Given this list of marker genes ACOX1, SETD5, PIKFYVE, SSBP2, DUSP6, RFX1, CTTNBP2, CDCA7L, RNF38, FHIP2A, SFXN1, XYLT2, FNIP2, CNIH1, KLHL14, RIMS2, LONRF3, GIT2, FKBP1A, NR4A3, GPR137C, PLEKHG3, HNF1B, SLC24A3, PRKAR2B, GOLGA4, TACC2, KLF4, PALLD, SLC10A7, DDX3Y, PAPSS2, BCL11A, CBLN4, RAB23, RAB3C, VWA5B2, NFYC, UBE2W, HYCC2, USP36, FMN2 (NCBI Gene Id 56776), DOCK5, MIA3, CBFA2T3, MMP10, ELOVL4, PPP1R37, TAGAP, DPP10, WASL, DSC2, C19orf12, GPC6, ADAMTSL3 (ADAMTS like 3), PIK3AP1, MBOAT2, RSBN1, ASPH, YIPF4, FOXN2 (NCBI Gene Id 3344), HIPK1, RNF180, OTUD4, PTGES2, ANKRD28, UBXN4, ITPRID2, CUX1, PITPNM2, SLC17A6, TWIST1, UBE2Z, TMF1, ELK4, CPNE8, ZFC3H1, FRY, SERTAD2, SOCS6, GLCE, FBXW7, KLHL29, OTUD3, MTMR9, EDEM1, NCKAP5, SLC4A8, HCN2, GNAQ, SLC12A5 (NCBI Gene Id 57468), SH3PXD2A, MPP1, GTF2A1 (general transcription factor IIA subunit 1), MAP3K20, PNISR, TNPO1, GOLGA7, DCAF6, DUSP10, RGS3, TPCN1, FBXO33, FHIP1B, TCF21, VPS4B, CSMD3, ARF1, ANP32E, RNF4, PCDH7, MIER1 (MIER1 transcriptional regulator), TAFA1, FCHO2, GATA6, IL36B, NUP43, PTPRK, CCDC186, MAP1B, AIDA, SLC9A7, NSF, MSR1, MFHAS1, SYNJ1, PPP1R12C, MAN2A1, PCMTD1, LIN54, SNAPC1, ZFHX4, IRS2, KLF8 (NCBI Gene Id 11279), JMY, SPTBN4, NKX2-4, NOX4, IBTK, MINAR1, NEFM, EPG5, SLC25A32 (NCBI Gene Id 81034), REXO1, PCGF3, PIK3R3, ARMC1, RANBP9, ZNF287, SEC31B, TWF1, REST, COL5A1, PUS7, KBTBD8, SEMA3A, GID4, CHCHD10, C6orf62, TMEM229A, COG3, SELENOT (selenoprotein T, NCBI Gene Id 51714), TSC1, GATA2, CDK16, TRIM36, UCHL5, MYCBP2, LYST, GRAMD2B, PDE10A, C8orf44-SGK3, NIPAL1, PCOLCE2, NEFH, UBASH3B (ubiquitin associated and SH3 domain containing B), FOSL2, ZDHHC5, ANKIB1, CACNA1I (calcium voltage-gated channel subunit alpha1 I), EVI5, FNBP4, PRRC2B, GPR158, PLEKHB2, SGK3, FZD10, SYN2, ESRP1, TTC9, DAAM1, GNPDA2, ST6GAL2, DSTYK, STX17, BSDC1, MAP2K4, ROBO2, KMT5B, HIVEP1, CPEB4, BCAT2, MED19, UGP2, NUFIP2, SLC38A2, ANKRD44, PTPRJ, MCL1, SOSTDC1, SNX13, MAGEC2, FAM81A, KLHL15, MAST4, ADAMTSL1, ATXN1 (NCBI Gene Id 7912), ZNF595, ZEB2, CADM2, STYX, DNAJB9 (DnaJ heat shock protein family (Hsp40) member B9), SLC32A1, RAD21, CDKL5, SNAP91, RPS6KA4, TMEM255A, SLX4, EOMES, RORA, ZNF230, BAZ2B, NF2, ACTC1, SERINC5, ITGA5, FBN1, PHTF2, PCYT1B (phosphate cytidylyltransferase 1B, choline), TEX2, TENT4A, OSBPL5, NIPBL, ATXN3, GLRA1, PDZD2, DUSP5, TBC1D8, DTX2, ALKAL2, ARRDC4, CIC, APPL1, PRSS12, EDEM3, PIAS4 (protein inhibitor of activated STAT 4), PAXBP1, DENND4B, C5orf24, PIK3CB (phosphatidylinositol-4,5-bisphosphate 3-kinase catalytic subunit beta), ARHGAP24, MORC3, FAM135A, ADAM19, GLYR1, ITGAV, SCAF11, GOLGA1, RBM47, ARPC2, DYRK2, PGBD2, ARHGEF17, SGPP1, BCL2L11, MEF2D, IDH1, DOCK9, ZNF721, FAM20C, RNF11, LUZP1, SLC25A36, CD69, NPC1, SCN8A, MTF1, ARRDC3, PKDCC (protein kinase domain containing, cytoplasmic), GRIA1, TEF, PHF3, G3BP2, LRCH1, GOLGA3, CNEP1R1, AFF1, SOX11, KLF2, ZNF532, SBNO1, MACIR, PPCS, SLC9A1, LATS2, DNAAF9, USP45, CPEB3, PAPOLA, BSN, MAPK8, MYH9, ASPN, GOLGA8A, TOB2, BTG2 (BTG anti-proliferation factor 2), PEAK1 (NCBI Gene Id 79834), TEAD1, DENND1B, LIMCH1, PHLPP2, EFR3A, NCAPH2, SLC7A11, FHL2, CLDN11, APBB2 (NCBI Gene Id 323), AFF3, PDZD8, COL1A2, LMBR1L (NCBI Gene Id 55716), TBL1XR1, TBC1D12, MMD, AGO3, C21orf91, GPBP1L1, PTGER4, COX20, RHPN2 (NCBI Gene Id 85415), COL19A1, ZNF521, SRPRA, INSIG1, DNAJB12, PIP5K1C (NCBI Gene Id 23396), PPP1R12A, NSMAF, PTPRO, GPR180, CXCL5, CCNC, SESN3, LHFPL2, TGIF1, BLTP1, MAP7D3, ATRX, FXR1, PCDH11Y, MFF, MYLIP, ITGA8, CELF2, PTPRD, MYO1B, ADGRF2P, AADACL3, ARID1B, RGL1, RIC1, MARCHF4, PLEKHA1, RAB8B, MYO5A, RAB14, DDX3X, HAND2, EPC2, PITPNA, CFAP263, SOX4, DUS2, PAX3, CHRM5, RNF44, SLC25A16, P3H3, SPRYD4, CD2AP, NKX2-3, NFYB, B3GALT2, ZFYVE21, ZFAND1, PTAR1, SH3D19, PAX9, MOAP1, GRM7, RBM27, NEFL, RGS17, RNF141 (ring finger protein 141), PIK3CA, NPNT, C11orf24, GRHL1, BCL11B, CALN1, TULP4, NSMF, FBXO28, ADCY3, PLXDC2, TPPP, BMPR2, ZC2HC1A, FNIP1, ADRB1, TOB1, ZNF827, LRRC1, HERPUD2 (NCBI Gene Id 64224), NRG1, ATP6V1B2, TRIO, JOSD1, HS3ST5, KAT2B, CCNJL, ZNF24, COL27A1, ELOA, KLHL11, MCOLN2, PTEN, STRN3, CLCN5, HIPK3, SCUBE3, PER2, TMEM267, SLC39A8, DMXL1 (NCBI Gene Id 1657), ERGIC2, IQGAP2, NOTCH1, PCDH11X, PSMD14, ANO8, ADAM10, RPL15, USP28, NEDD4L, FAM24A, XPNPEP3, CPEB2, SERTAD3, TET2, ZNF385D, ZNF804A, SNN, ATG14, RBPMS2, ITPR1, ABHD13, FMR1, ITGA6, TECPR2, WWP2, ATP7A, BAHCC1, CASD1, KLHDC10, GFPT2, here is a description of the gene set: Genes predicted to be targets of miRBase v22 microRNA hsa-miR-92a-3p in miRDB v6.0 with MirTarget v4 prediction scores > 80 (high confidence targets). species: Homo sapiens Human Gene Set: MIR92A_3P from publication Chen Y, Wang X (PMID 31504780)